Given this list of marker genes Ern2, Qrich1, Bfar, Optn, Atf3, Nck2, Crebrf, Ufl1 (NCBI Gene Id 67490), Casp12, Tmtc4, Ficd, Hsf1, Serp2, Eif2a, Eif2s1, Ero1a, Parp16, Daxx, Abca7, Umod, Nck1, Parp8, Asb11, Derl3, Nfe2l2, Bak1, Abcb10, Manf, Hspb8, Tmem33, Tm7sf3, Tbl2, Bag3, Tmbim6, Ccnd1, Atf4, Eif2ak3, Akt2, Atf6, Creb3l1, Ptpn1, Bhlha15, Atad3a, Ern1, Edem2, Bok, Hspa5, Creb3, Derl2, Rhbdd1, Akt3, Herpud2, Ptpn2, Pigbos1, Dnajb9, Hspd1, Derl1, Pik3r1, Cops5, Eif2ak2, Akt1 (NCBI Gene Id 268604), Parp6, Ermp1, Igtp (NCBI Gene Id 16145), Amfr, Rpap2, Ppp1r15a, Os9, Ifng, Vapb, Yod1, Erlec1, Xbp1, Edem3, Serp1, Atf6b, Cdk5rap3, Pmp22, Tmed2, Bax (NCBI Gene Id 12028), Dnajc10, Eif2ak4, Ddit3, Herpud1, Wfs1, Pacrg, Pdia6, Agr2, Stc2, Selenos, Tmbim4, Ddrgk1, Dnajc3, Stub1, here is a description of the gene set: Any process that results in a change in state or activity of a cell (in terms of movement, secretion, enzyme production, gene expression, etc.) as a result of an unfolded protein stimulus. Mouse Gene Set: GOBP_CELLULAR_RESPONSE_TO_UNFOLDED_PROTEIN studied in species Mus musculus